Given this list of marker genes INHBA, ANTXR1, FGFR1, SLC25A3, CCNB1IP1, ADPRM, PGAM2, UTP4, TUBA4A, PRSS23, COTL1, GJA1, PIM3, POLD2, RPL10A, UQCR10, HDGF, RAN, PRMT1, SNRPD2, HHIP, MGST3, GASK1B, XAB2, MORF4L2, KDELR2, OAT, TNFRSF10D, CCT3, HSP90AB1, PA2G4, CCT4, PPIAP15, METTL9, EIF4G2, NDUFA4, RHOC, TIMM17A, TXNDC5, ESM1, TPT1, PRKAG2, HDAC2, CSE1L, PRDX1 (NCBI Gene Id 5052), EI24, GADD45A, RPL6, KRT7, APEX1, CCT5, SSR2, TPX2, HMGCL, ODC1, TFRC, SMYD2, DKK1, NT5DC2, DAB2 (NCBI Gene Id 1601), SMS, DESI2, LGALS1, H2AZ1, APLN, RTN4, THSD4, ATP5PB, FABP5, RGS4, MMP10, CD34, CABLES1, ARHGDIB, RPSA, NQO1 (NCBI Gene Id 4834), ILF2, ANGPTL2, CTNNAL1, RPS3A, HSPD1, PRCP, RPLP0, MICAL2, YWHAQ, VWF, PON2, here is a description of the gene set: To investigate the potential molecular mediators of tissue-specific recruitment, we explored the influence of different cytokine challenges on gene expression regulation in five primary endothelial cells (ECs), representing two different phenotypes: iliac artery and aortic (macrovascular); lung, colon and dermal (microvascular). We challenged ECs with cytokines that elicit different patterns of inflammatory and immune responses in immune cells: tumor necrosis factor (TNF-alpha), interferon-gamma (IFN-gamma) or interleukin-4 (IL-4), and used microarrays containing approximately 40,000 unique cDNAs, to assess changes in differential gene expression relative to untreated cells. Five hundred and sixty three sequences changed by at least 2.5 fold in one or more of the 15 possible EC /cytokine combinations. The list included highly regulated adhesion molecules, chemokines, cytokines, metalloproteases, and IFN-gamma-induced genes. Overall, IFN-gamma caused the largest number of gene expression changes and its profile was least correlated with IL-4. In addition to clusters that were predominantly EC/cytokine specific, we also observed several clusters that were regulated by more than one cytokine across several ECs. Furthermore, we identified genes that were reciprocally expressed in response to different cytokines that could serve as markers of inflammatory and immune expression. These results confirm the importance of microenvironment in primary ECs that could have important applications in developing targeted therapies for vascular diseases. studied in species Homo sapiens Genes down-regulated in five primary endothelial cell types (lung, aortic, iliac, dermal, and colon) by IFNG. Human Gene Set: SANA_RESPONSE_TO_IFNG_DN from publication Sana TR, Janatpour MJ, Sathe M, McEvoy LM, McClanahan TK (PMID 15749026)